The following is a description of a gene set: species: Mus musculus Mouse Gene Set: GOMF_PHOSPHOFRUCTOKINASE_ACTIVITY Catalysis of the transfer of a phosphate group, usually from ATP, to a phosphofructose substrate molecule., and this is the list of marker genes: Pfkp, Pfkfb3, Pfkfb2, Pfkl, Pfkfb1, Pfkfb4 (NCBI Gene Id 399643), Pfkm